The following is a description of a gene set: Cyclin A:Cdk2 plays a key role in S phase entry by phosphorylation of proteins including Cdh1, Rb, p21 and p27. During G1 phase of the cell cycle, cyclin A is synthesized and associates with Cdk2. After forming in the cytoplasm, the Cyclin A:Cdk2 complexes are translocated to the nucleus (Jackman et al.,2002). Prior to S phase entry, the activity of Cyclin A:Cdk2 complexes is negatively regulated through Tyr 15 phosphorylation of Cdk2 and also by the association of the cyclin kinase inhibitors (CKIs), p27 and p21. Phosphorylation of cyclin-dependent kinases (CDKs) by the CDK-activating kinase (CAK) is required for the activation of the CDK2 kinase activity. The entry into S phase is promoted by the removal of inhibitory Tyr 15 phosphates from the Cdk2 subunit of Cyclin A:Cdk2 complex by the Cdc25 phosphatases and by SCF(Skp2)-mediated degradation of p27/p21 (see Ganoth et al., 2001). While Cdk2 is thought to play a primary role in regulating entry into S phase, recent evidence indicates that Cdk1 is equally capable of promoting entry into S phase and the initiation of DNA replication (see Bashir and Pagano, 2005). Thus, Cdk1 complexes may also play a significant role at this point in the cell cycle. Reactome Pathway: Cyclin A:Cdk2-associated events at S phase entry part of: S Phase studied in species Homo sapiens, and this is the list of marker genes: CDK2, CDC25B, PSMD3, CCND1, SEM1, TFDP1, PSMA6, RBBP4, AKT2, FZR1, AKT3, PSMA1, ADRM1, PSMC1, E2F4, UBB, UBC, PSMA3, E2F1, SKP2, UBA52 (ubiquitin A-52 residue ribosomal protein fusion product 1), CDKN1A, PSMC2, PSMB2, PSMC4, PSMD1, PSMC6, CCNA1, CDKN1B, LIN54, PSMD2, CDK7, RPS27A, CCNH, TFDP2, E2F5, PSMB7, PSMD14, PSMB6, CUL1, PSMD12, MAX, CDC25A, PSMB4, PTK6, AKT1, PSMB3, PSMD7, PSMD8 (NCBI Gene Id 5714), CKS1B, WEE1, CCNA2, PSMC5, CABLES1, PSMC3 (NCBI Gene Id 96121), MNAT1, CCNE2, PSMD6, PSMA4, PSMB5, CDK4, MYC, PSMB1, SKP1, PSMD11, LIN9, LIN52, PSMA7, LIN37, RB1, RBL2, PSMA5, PSMA2, CCNE1, PSMD13